The following is a description of a gene set: from publication Yevshin I, Sharipov R, Kolmykov S, Kondrakhin Y, Kolpakov F (PMID 30445619) species: Homo sapiens Genes containing one or more binding sites for (ZBED4) in their promoter regions (TSS -1000,+100 bp) as identified by GTRD version 20.06 ChIP-seq harmonization. Human Gene Set: ZBED4_TARGET_GENES, and this is the list of marker genes: CDC25C, KXD1, IQCH, PSMC2, STK11IP, POLD2, SEC61G-DT (NCBI Gene Id 100996654), ZNF709, MFSD11, POLR1E, MST1P2, BRI3, KRIT1, ZW10, SHISA5, IER3 (immediate early response 3), DDX41, DGKA, IFT122 (NCBI Gene Id 55764), OXLD1 (NCBI Gene Id 339229), LNCRNA-IUR, PLAUR, SPC24, NPAT (NCBI Gene Id 8067), C3orf38, USP5, HEATR5A, ZNF57, CIAO3, STXBP5-AS1, LTBR, PPP2CA, USP37, HEATR5A-DT, NABP1, CAPS2, RBM14, C2orf15, MCM7, SFXN2, FGFR1OP2, DDR1, KPTN, TRMT61B, ZNF687-AS1, SNRPA1, PI4KB, FER, RBM6, SH2D4A, TDG, ITGB1-DT, MKLN1-AS, MORN1, SMDT1, PDAP1, YPEL5, CNOT9, RAB27A, LSM1, ATG101, MIR3661, RIMOC1, GALE, CALCOCO1 (NCBI Gene Id 57658), WBP2, ZKSCAN5, CAAP1, DFFB, HMGB3P22 (NCBI Gene Id 730702), RPLP1, ANKIB1, PDE7A, CMBL, MIRLET7IHG, PPIL3, DCAF17, TSACC, DHPS, CCDC103, EMP1, NAPA-AS1, POLD3, SEC61G, STXBP1, COG3, SPRED2, DNAJC14, OIP5, DCP2, ITGA6-AS1, PIGO, CCDC137, NANP, TM2D1, UQCRQ (NCBI Gene Id 27089), PHF14, ARL3, AP4M1, KRT8, MAN1B1, LINC02361, PPP2CA-DT, SNORD84, TSPAN13, GLIPR1L2 (GLIPR1 like 2), UTP11 (NCBI Gene Id 51118), MNS1, FAM220A, CENPS-CORT, PIGO-AS1, RBM14-RBM4, FAM114A2, CLK1, STK19, ATM, NASP, LINC01023, ABHD11, CRY1, MDM2, CRB3, MLH3, TRIM52-AS1, RPP38, NOP16, POLG-DT, NUSAP1, BUD31, TATDN1, NRL, WDR55, CHD2, TEX9, RBBP4, UQCC1, SESN3, HARS2, MFAP3, NDUFAB1, SNAP23, SP2-AS1, GDF9, PIGB, ADAM15, ZNF337-AS1, PIGBOS1, ANXA2R-OT1, RPS27A, LIPT2-AS1, CENPS, CEP104, DGCR8, PDE7A-DT, C2CD5, LRRC46, PYURF, SHB, RPS17, VMP1, SH3RF2, UBE3B, RAB11FIP1, INTS13, MFN2, TMEM87A, RAB4B, DXO, CD27-AS1, NACA, TUFT1, CANX, NDUFAF6, ZBTB8OS, CCNH, CENPJ, SRSF2, MBD4, PSEN1, SF3B1, PPP1R18, PLK2, GANC, NGRN, RMC1, RBM12B-DT, NIF3L1, S100A16, CDCA3, H2AC11, RAD51, MMADHC-DT, DDX39B, MRPS27, ARID4B, SOX2-OT, TTLL13, STAM2 (NCBI Gene Id 51453), ETS2, HNRNPA1, POLG, SRSF10, KCTD10, NUP42, MLEC, IRF6, C1orf159, RER1, ELP3, ACAA1, LPIN3, TMEM139, HERC3, NDC1, ARPC5L, GSPT1, ZNF384, GRK6, DIMT1, TSGA10, GGPS1, SLC30A4-AS1, KIF20A, BRF1, GPBP1, EFTUD2, IPO11, RPS19BP1, CLHC1, PWWP2A, ZNF687, NUP155, SNRPA1-DT, SLC16A13, NDUFA12, UBE2S, CYSTM1, OCLN (occludin), LRFN4, GEMIN5, CGGBP1, FAM219B, C12orf76, TBC1D15, RHOA, SLC11A2, GET4, NCOR1, PRR15-DT, MND1, CC2D1B, GTF2IRD1P1, AAGAB, UPP1, VPS26C, PARP6, TSPAN1, YARS2, TTBK2, FAM187A, CROCCP2, NCBP2AS2, NELFA, SHROOM3, WASF2, DCAF11, RPS29P16, BAG4, DDX39B-AS1, MARS1, RBM45, TAPBPL, TECPR1, DCAF8, TERC, MINDY1, NCBP2, PPA1, PTRH2 (peptidyl-tRNA hydrolase 2), CLDN3, IDE, EIF1, PSMA5, FAM53C, TMEM19, METTL8, MKLN1, KIZ, ITGB1, MRPS16 (NCBI Gene Id 64959), RPL35, RNF135, PNPO, BRD8, H2BC11, DNAJC19, HIGD2A, HARS1, TMEM198B, TCTA, PCGF1, LIPT2, TMEM52, DHDDS, EIF4B, VPS50, PARS2, TRIM52